Given this list of marker genes Coasy, Pank3, here is a description of the gene set: part of: Vitamin B5 (pantothenate) metabolism This event has been computationally inferred from an event that has been demonstrated in another species.<p>The inference is based on the homology mapping from PANTHER. Briefly, reactions for which all involved PhysicalEntities (in input, output and catalyst) have a mapped orthologue/paralogue (for complexes at least 75% of components must have a mapping) are inferred to the other species. electronically inferred by orthology from the curated human pathway studied in species Mus musculus Reactome Pathway: Coenzyme A biosynthesis